Given this list of marker genes PSMC4 (proteasome 26S subunit, ATPase 4), PSMB6, UBE2M (NCBI Gene Id 9040), SKP1, UBA3 (NCBI Gene Id 9039), ADRM1, PSMB4, PSMC6, CCL17, PSMB3 (proteasome 20S subunit beta 3), BTRC, CHUK (component of inhibitor of nuclear factor kappa B kinase complex), PSMA4, PSMA2, PSMD14, PSMA1, UBB, PSMB1, PSMD7, NFKB2, PSMD12, PSMC2 (NCBI Gene Id 5701), UBC (NCBI Gene Id 7316), PSMB2, CUL1, PSMB5, PSMC3, PSMA5, PSMA6, PSMC5 (NCBI Gene Id 5705), MAP3K14, PSMD13, PSMD1, SEM1, RELB, PSMC1, PSMD6, PSMD8, PSMA7, RELA, CCL22, PSMA3, PSMD11, PSMD2, FBXW11, PSMD3, UBA52 (NCBI Gene Id 7311), RPS27A, PSMB7, here is a description of the gene set: part of: CLEC7A (Dectin-1) signaling Reactome Pathway: Dectin-1 mediated noncanonical NF-kB signaling In addition to the activation of canonical NF-kB subunits, activation of SYK pathway by Dectin-1 leads to the induction of the non-canonical NF-kB pathway, which mediates the nuclear translocation of RELB-p52 dimers through the successive activation of NF-kB-inducing kinase (NIK) and IkB kinase-alpha (IKKa) (Geijtenbeek & Gringhuis 2009, Gringhuis et al. 2009). Noncanonical activity tends to build more slowly and remain sustained several hours longer than does the activation of canonical NF-kB. The noncanonical NF-kB pathway is characterized by the post-translational processing of NFKB2 (Nuclear factor NF-kappa-B) p100 subunit to the mature p52 subunit. This subsequently leads to nuclear translocation of p52:RELB (Transcription factor RelB) complexes to induce cytokine expression of some genes (C-C motif chemokine 17 (CCL17) and CCL22) and transcriptional repression of others (IL12B). studied in species Homo sapiens